The following is a description of a gene set: Mouse Gene Set: GOBP_MICROGLIAL_CELL_MEDIATED_CYTOTOXICITY The directed killing of a target cell by a microglial cell. studied in species Mus musculus, and this is the list of marker genes: Itgam, Tyrobp, Spi1, Cx3cr1, Stap1